Given this list of marker genes Oxct2a, Cyp4f14, Oxct2b, Abhd16a, Nudt7, Abcd1, Dpep2, Lypla2, Hpgd, Fitm2, Cyp4f15, Acat1, Oxct1, Acot7, Nudt8, Cyp4f13 (cytochrome P450, family 4, subfamily f, polypeptide 13), Acot2, Nudt19, Cyp4f18, Dpep1, Cyp4f40 (NCBI Gene Id 631304), here is a description of the gene set: studied in species Mus musculus The chemical reactions and pathways resulting in the breakdown of fatty acid derivative. Mouse Gene Set: GOBP_FATTY_ACID_DERIVATIVE_CATABOLIC_PROCESS